The following is a description of a gene set: Human Gene Set: GOBP_POSITIVE_REGULATION_OF_REACTIVE_OXYGEN_SPECIES_BIOSYNTHETIC_PROCESS studied in species Homo sapiens Any process that activates or increases the frequency, rate or extent of reactive oxygen species biosynthetic process., and this is the list of marker genes: CLCN3, TLR4, CD36, MIR675, ZNF205 (NCBI Gene Id 7759), ADGRB1, FOXO3 (NCBI Gene Id 2309), PARK7, GRIN1 (glutamate ionotropic receptor NMDA type subunit 1), MIR24-1, LCN2, FAS, SOD2, ADCY10, DUOXA1, RAB27A, SLC5A3, CYBA, DUOXA2, PLCG2, TLR6